Given this list of marker genes ARF6, PPFIA2, DLG1, CSMD2, SHANK1, PRICKLE1, here is a description of the gene set: Human Gene Set: GOBP_MAINTENANCE_OF_POSTSYNAPTIC_DENSITY_STRUCTURE species: Homo sapiens A process which maintains the organization and the arrangement of proteins in the presynaptic density.